Given this list of marker genes PITX2, PHLDA2, ME1, HLA-C, TFAP2A, CTH, SELENOP, MDFIC, DYNLT3 (NCBI Gene Id 6990), DAB2, DLX2, ANXA1, RBP1, HTRA1, GPC4 (glypican 4), EMP3, MYC, MN1, PAWR, POU4F1, HLA-E, CCN2, CCNO, CD55, CCND2, MICB, GADD45B (NCBI Gene Id 4616), NID1, here is a description of the gene set: Human Gene Set: RORIE_TARGETS_OF_EWSR1_FLI1_FUSION_UP from publication Rorie CJ, Thomas VD, Chen P, Pierce HH, O'Bryan JP, Weissman BE (PMID 14973077) species: Homo sapiens ES/PNET (Ewing sarcoma; primitive neuroectodermal tumors) markers up-regulated in neuroblastoma cell lines expressing ESWR1-FLI1 fusion protein. Neuroblastoma (NB) and the Ewing sarcoma (ES)/peripheral primitive neuroectodermal tumor (PNET) family are pediatric cancers derived from neural crest cells. Although NBs display features of the sympathetic nervous system, ES/PNETs express markers consistent with parasympathetic differentiation. To examine the control of these differentiation markers, we generated NB x ES/PNET somatic cell hybrids. NB-specific markers were suppressed in the hybrids, whereas ES/PNET-specific markers were unaffected. These results suggested that the Ews/Fli-1 fusion gene, resulting from a translocation unique to ES/PNETs, might account for the loss of NB-specific markers. To test this hypothesis, we generated two different NB cell lines that stably expressed the Ews/Fli-1 gene. We observed that heterologous expression of the Ews/Fli-1 protein led to the suppression of NB-specific markers and de novo expression of ES/PNET markers. To determine the extent of changes in differentiation, we used the Affymetrix GeneChip Array system to observe global transcriptional changes of genes. This analysis revealed that the gene expression pattern of the Ews/Fli-1-expressing NB cells resembled that observed in pooled ES/PNET cell lines and differed significantly from the NB parental cells. Therefore, we propose that Ews/Fli-1 contributes to the etiology of ES/PNET by subverting the differentiation program of its neural crest precursor cell to a less differentiated and more proliferative state.